Given this list of marker genes Otub2, Mvb12a, Tollip, Rnf185, Mdm2, Tsg101, Ascc2, Dhx16, Uchl3, Wdr48 (NCBI Gene Id 67561), Ubap1l, Trp53inp2, Ddi2, Stam, Cks1brt, Dnajb2, Nploc4, Klf1, Ikbkg, Uchl4, Cks1b, Usp13, Rae1, Dnaaf10, Rnft1, Ubxn7, Rad23a, Uchl1, N4bp1, Rbck1, Cuedc2, Marchf7, Tnfaip3, Nod1, Otulinl, Nedd4, Tab3, Usp16, Bub3, Tab2, Fbxw7, Trim32, Uevld (UEV and lactate/malate dehyrogenase domains), Rnf168, Tom1l2, Ubxn11, Jarid2, Top2a, Tax1bp1, Map3k7, Rnf8, Faap20, Cuedc1, Vps36, Nsfl1c, Eps15, Sharpin, Smarcad1, Ubxn2a, Optn, Ubap1, Hspb1, Zfand2b (zinc finger, AN1 type domain 2B), Stam2, Cxcr4, Sirt2, Rnf31, Gga2, Ubxn2b, Nbr1, Nod2, Rad23b, Ubr5, Faf1, Ube2n, Prkn, Sprtn, Plaa, Rnf19b, Hgs, Ubxn1, Ubxn10, Ilrun, Ubxn8, Usp5, Nup62, Vps28, Tom1l1, Sqstm1, Hdac6, Ube2l6, Aup1, Faf2, Gga3, Gga1, Otub1 (NCBI Gene Id 107260), Fbxo7, Cks2, Amfr, Birc2, Tom1, Smad3, here is a description of the gene set: Mouse Gene Set: GOMF_UBIQUITIN_BINDING studied in species Mus musculus Binding to ubiquitin, a protein that when covalently bound to other cellular proteins marks them for proteolytic degradation.